Given this list of marker genes GSTM1, EPHA5, LDLRAP1, RASA3, CHRNG, KLHDC1, PRR16, SLC22A13, PARP11, NR1I3, SLCO6A1, ITGB7, ELOVL7, LASP1 (NCBI Gene Id 3927), ZBTB7C, PPIP5K1, ENO3, PTGER2, CMPK2, TRIM34, HOXC8, FGF12, ADAMTSL2, IFIH1 (NCBI Gene Id 64135), IGFBP4, SPTB, PAX5, C22orf23, GPRIN2, TMIE, TERT, DENND2D (NCBI Gene Id 79961), GPR135, PTPN22, LZTR1, SAMD9L, SMURF2, BNIP5, UGT8, KDM4D, LITAF, LMNTD2, SLC25A12, AK7, RGMB, APPL2, NHSL3, TNFSF8, SPATA6L (NCBI Gene Id 55064), PCDH7, MMP11, MLYCD, POU4F3, FGF18, PTX3, SLC44A4, SARM1, CPEB4, NRN1, TMEM151A, CYP4V2, ABCD1, DNAH8, CCR3, CRMP1, ESYT1, C2orf80, GRIN3B, DNAI2 (dynein axonemal intermediate chain 2), ZFP41, REG3A, AP1G2, SLC16A13, OSM, TRIM66 (tripartite motif containing 66), AKR1C2, SLC25A45, PANX1, BICDL2, SLFN5, PPP1R3F, ALAS1, TEX38, CCKBR, HVCN1, SPON2, POU3F2, TRPM1, ALS2CL, ANK2, TSPAN9, IFT80, PTHLH, DNAH5, LYPD8, HAS3, PRR15 (NCBI Gene Id 222171), IRF9, SDC3, AADAT, KHNYN, TMEM71, LRRC75A, STPG3 (NCBI Gene Id 441476), E2F7, ADORA1, C1QL2, PDK4, OSCAR, B4GALT5, HMX3, REC8, CDX4, TC2N, ADH1C, ADD3, C19orf12, PELI1, SCNN1B, HERC6, TANK, KLF14 (NCBI Gene Id 136259), TBX5, FUT1, MB, SETX, GRM8, TRPC4, ACAP1, IL17RA, VTN, ADM2, ANKRD23, GBP6, CSRP3, SEMA4F, ARR3, PKP4, RGS16, CD86, NDRG3, PTGER3, KCNA6, NLRC5, MAGEB16, MLC1, ENSG00000286190, PYROXD2, AMPD3, KCTD14, ABCA1, HOXC4, PXYLP1, IGFLR1, IRGM, TAP1 (NCBI Gene Id 92050), IFI44, PCK2, PARP14, TEX19, CAST, ADAMTS6, PPP3CC, PSD2, FAP, RP1L1, FOLR2, EGFR, PDE3B, MAP2, AKR1D1, TNFRSF9, SYNE2, RIMBP3C, CLDN22, MGAT4EP, DHX58, RBMXL2, ST3GAL5, CSNK1G3 (casein kinase 1 gamma 3), TRAF5, OAS2, LHX6, DTX3L, CA5A, ARHGAP20, SOX11, FAAH, CCND2, LSAMP (limbic system associated membrane protein), TNFRSF25, GRAMD4, OSBPL10, ST8SIA6, CNMD, IGSF11, RPF2, ASB5, KHDRBS3, ITGAM, here is a description of the gene set: Human Gene Set: GSE30083_SP1_VS_SP2_THYMOCYTE_DN After positive selection in the thymus, the newly generated single positive (SP) thymocytes are phenotypically and functionally immature and undergo apoptosis upon antigen stimulation. In the thymic medullary microenvironment, SP cells progressively acquire immunocompetence. Negative selection to remove autoreactive T cells also occur at this stage. We have defined four subsets of CD4 SP, namely, SP1, SP2, SP3, and SP4 that follow a functional maturation program and a sequential emergence during mouse ontogeny.We used microarray to detail the global programm of gene expression during the maturation of murine CD4 single positive thymocytes species: Homo sapiens from publication Teng F, Zhou Y, Jin R, Chen Y, Pei X, Liu Y, Dong J, Wang W, Pang X, Qian X, Chen WF, Zhang Y, Ge Q (PMID 22022412) Genes down-regulated in comparison of SP1 thymocytes versus SP2 thymocytes.